The following is a description of a gene set: studied in species Homo sapiens Pathway Definition from KEGG: AREG -> EGFR -> PI3K -> PIP3 -> AKT -> MTOR -> S6K Human Gene Set: KEGG_MEDICUS_REFERENCE_AREG_EGFR_PI3K_SIGNALING_PATHWAY AREG-EGFR-PI3K signaling pathway. Pathway ID: N00284. Pathway type: Reference. Pathway class: nt06260 Colorectal cancer., and this is the list of marker genes: PIK3CA, PIK3CD, AKT1, AREG, AKT2, MTOR, EGFR, AKT3, PIK3CB, RPS6KB1, RPS6KB2